Given this list of marker genes Calhm2, Nr4a1, Myo18a, Lrfn5, Pla2g5, Tlr9, Sphk1, Lgals9, Wnk4, Bpi, Casp1, Il33, Wnt5a, Thbs1, Jak2, Tlr3, Adgrf5, Snca, Snhg20, Mfhas1, Fcer2a, Hspa12a (heat shock protein 12A), C1qa, Syk, Grn, Cx3cl1, Clu, Crtc3, Kcnn4, Tlr2, Nmi, Lbp, Tyrobp (NCBI Gene Id 22177), Abcc1, Havcr2, Ager, Il10, Cst7, Jmjd6, Slc11a1, Sbno2, Lcn10, Lrrk2, Kars1, Ulbp1, Pparg, App, Ifng, Itgam (NCBI Gene Id 16409), Il4ra, Dysf, Naglu, Hamp, Ifnb1 (interferon beta 1, fibroblast), Cx3cr1, Hmgb1, Tnip2, Cd200, Raet1d, Ifngr1, Pla2g10, Tafa3, Il1rl1, Cd1d1, Ighe, Pla2g4a, Irgm1, Syt11, Trex1, Cebpa, Plcg2, Mmp8, Tmem229b, Aif1, Kcnj8, Jun, Csf1r, Stk39, Rora (NCBI Gene Id 319897), Slc7a2, Ttbk1 (NCBI Gene Id 106763), Cd84, Tlr1, Trim55, Nr1d1, Il13, Ctsc, Trem2, Nampt, Gpr137b, Mcub, Fam76b, Ifngr2, Atm, Ldlr, Pja2, Stap1, Ifi35, Muc5b, Tlr4, C5ar1, Mir7116, Mir505, Shpk, Nr1h3, Tnf, Sucnr1, Il4, Trpv1, Ticam1, Tmem106a, Tlr6, Prkce, Hspa4, Tff2, Epsti1, Hspd1, Foxp1, Edn2, Jund, Pla2g3 (phospholipase A2, group III), here is a description of the gene set: A change in morphology and behavior of a macrophage resulting from exposure to a cytokine, chemokine, cellular ligand, or soluble factor. studied in species Mus musculus Mouse Gene Set: GOBP_MACROPHAGE_ACTIVATION